The following is a description of a gene set: The series of molecular signals initiated by a ligand binding to a cell surface pattern recognition receptor (PRR). PRRs bind pathogen-associated molecular pattern (PAMPs), structures conserved among microbial species. Mouse Gene Set: GOBP_CELL_SURFACE_PATTERN_RECOGNITION_RECEPTOR_SIGNALING_PATHWAY species: Mus musculus, and this is the list of marker genes: Wdfy1, Nfkbia, Traf6, Ticam1, Oas1a, Irak1, Tnfaip3, Irak2, Mfhas1, Chuk, Tlr2, Lbp, Ffar2, Znrf1, Arf6, F2rl1, Lrrfip2, Peli1, Cyba, Sqstm1, Dab2ip, Trim32, Appl2, Traf3, Appl1, Ninj1, Tmem126a, Oas1f, Oas1c, Oas1d, Tax1bp1, Naglu, Nod2, Tbk1, Rela, Trem2, Oas1h, Ltf, Ptpn22, Ly96, Tnip3, Tirap, Myd88, Tnip2, Tlr4, Tlr6, Prkce, Ecsit, Pik3ap1, Scimp, Nr1d1, Oas1b, Syk, Mbl2, Pik3r1, Clec7a, Ripk2 (NCBI Gene Id 70170), Tril, Rab11fip2, Fcna, Oas1g, Irf3, Hmgb1, S100a14, Tlr5, Tlr1, Pja2, Ticam2 (NCBI Gene Id 225471), Letmd1, Fcnb, Map3k7, Ifi35, Acod1, Cd14 (NCBI Gene Id 12475), Nmi, Oas1e, Nr1h3, Lyn, Rab7b, Bpifb1